The following is a description of a gene set: Mouse Gene Set: SP5_TARGET_GENES Genes containing one or more binding sites for (Sp5) in their promoter regions (TSS -1000,+100 bp) as identified by GTRD version 20.06 ChIP-seq harmonization. from publication Yevshin I, Sharipov R, Kolmykov S, Kondrakhin Y, Kolpakov F (PMID 30445619) studied in species Mus musculus, and this is the list of marker genes: Pycr3 (NCBI Gene Id 67195), Raph1, Tiam1, Rtn4, Ajuba, Mxd3, B3gnt5, Tcea1 (NCBI Gene Id 21399), Fhl3, Arhgef2, Gas2l1, Igsf1, Ube2ql1, 1700066B17Rik, Cyyr1, Kcnb1, Maoa, 3110083C13Rik, Smox, Fars2, Pkib, Fgfr1, Resf1, Naprt, Srpk1, 2310074N15Rik, Wdr76, Irx2, Nyap1, Pabpc1, Fgfr4, Edn2 (endothelin 2), Ifitm1, Bcap31, Mef2c, Usp27x, Gsn, Lrba, Phyhd1, C1ql4, Agps, Pnkd, Lama1, Map2k4, Gm15567, Caprin2, Fzd2, Eea1, Itga2b, Gm5533, Inpp5k, Mertk, Prox1, Gm11733, Acy1, Tesk1, E2f5, Gm25894, Paqr8, Dst, Gng13, Plpp3, Brsk1, Hpcal1, Gm23470, Add3, Syne2, Emilin1, Plin2, Islr, Kctd5, Impdh2, Dcakd, Rnf44, Ggnbp2, Gm26708, Igf2r, Cpeb2, Pald1, Ogfrl1, Rbpms, Elf1, Gmfg, Yap1, C130083M11Rik, Btbd2, Ccdc71, Mov10, Gm10863, Unc5a, Arhgap12, Naalad2, Nrtn, Nr6a1, Tmprss2, Mir1943, Zdhhc20, Ccdc9, E2f1, C2cd2l, Unc119, Haglr, Gm2a, Nectin3, Esd, Kcnn2, Prr29, Has3, Pkd1, Slc29a1, Cln6, Lmbrd2, Zfp551, Megf8, Ldlrap1, Gja1, Rgs3, Itprid2, Rassf10, Dok4, Ift57, Adamts6, Fam169b, Anapc7, Ccnd2, Traf4, Ephb3, Foxn3, Gm24432, Nkiras2, Tubg1, Manea, Fbxo21, Vkorc1l1, Ctif, Greb1, Slc30a10, Tbc1d16, Nfkbiz, Taf8, Pcgf5, 2610528J11Rik, Nckap5l, Dnaaf5, Itpka, Gm10748, Scrt1, Kmt5c, Rian, Grb2, Dock9 (dedicator of cytokinesis 9, NCBI Gene Id 320710), Hexa, Snapc2, Chaf1b, Tmeff1, Set, Phldb1, Col16a1, Tmem198, Csnk2a1, Tma16, Uchl1, Mapk8ip2, Slc2a1, Gm26881, Elovl6 (ELOVL fatty acid elongase 6), Nfia, Vamp4, Atp13a3, Nectin2, Metrnl, Tbl1xr1, Tead2, Gm20109, Galk1, Hid1, Ripk2, Sertad1, Copg2, Usp31, Gatad2a, Ccng2, Actr2, Pkm, Rgs12, A530072M11Rik, Mpc2 (mitochondrial pyruvate carrier 2), Pim1, Fstl1, Snx30, Tppp, Trip12, Cpz, Septin9, Anks1 (NCBI Gene Id 224650), Cyp3a13 (NCBI Gene Id 13113), Arhgap18, E130018N17Rik, Pef1, Hspbp1, Vgll3, A330074K22Rik, Mindy2, Sox12, Mtss2, Arhgap1, Gm26224, Wdr45b, Tsga10, Adra2b, 1500002C15Rik, Tcn2, Ppif, Dhx35, Eif1a, Gfra2, Lsp1 (NCBI Gene Id 16985), Abhd17c, Pipox, Spint2, Asxl1, Tpbgl, Gja5, Gm14379, Serpina3i, C2cd2, Pam, 5730471H19Rik (RIKEN cDNA 5730471H19 gene), Trim62, Bcam, Ogfr, Nes, Gpr157, Tns1, Sult5a1, Fzd10, 4930544D05Rik, Sirpa, Plcxd1, Prdm9, Map3k14, Gm9889, Cnpy1, Ern1, Cdkn2d, Fbxl3, Trim41, Atl2, Slc16a9 (solute carrier family 16 (monocarboxylic acid transporters), member 9), Apbb2, Scaf1, Mycn, Gpat4, AW551984 (NCBI Gene Id 244810), Trim21, Lyrm4, Eomes, 1700041I07Rik, Trim29, Adamts9, Adamts15, Npm3, Ddx20, Mir8102, Trerf1, Jph4, Adprh, Ccdc40, Mir484, Uap1l1, Tmx4, Trp53cor1, Fmo5, Frmd6, Gm25855, Svop, Socs2, Psma2, Spsb1, Tmem26, Cxcl12, Mir135b, Ptpn4, Xylt2, Glra1, Bri3, Spmip8, Plekhh2, Wipf3, Hdac5, Arf1, Otud1, Adamts16, Ddr1, Klhdc10 (NCBI Gene Id 76788), Gcnt1, Bcl3, Speg, Krt19, Mir7240, Mapk8, Emx2, Col13a1, Mtmr4, Pdlim1 (PDZ and LIM domain 1 (elfin)), Tmem151a, Zfp804b (zinc finger protein 804B, NCBI Gene Id 207618), Ankle1, Mgarp, Etv1, Bmp7, Mir3098, Eva1b, Snx21, Lypd1, Ppp1r9b, a, Hs6st1, Cd300lg, Slco4a1, Elk4, Zswim6, Sh2d3c, Dleu2, Macrod2, Rbm38, Gm8177, Notch1, AI480526, Fbxw8, Thra, Fnbp1, Tspan14, Evx1os, Chchd7, Marf1, Gm17344 (NCBI Gene Id 115486898), Has2, Nudt7, Tpst2, Snx6, Gm16084, Arl4c, Slc17a5, Mir1191b, Prox1os, Ppdpf, Atp9b (ATPase, class II, type 9B), Gm23034, Setd1a, Phc1, Mfsd6l, Gse1, Zfp652, Spire2, Ndufa4l2, Gpr21, Klf10, Pdzk1, Jarid2, Trrap (NCBI Gene Id 640386), Car14, Tmem132c, Hycc2, Mir499, Zfp367, Tyro3, Tpd52, Ncf2, Zfp687, Kazn (NCBI Gene Id 71529), Cyrib, P2ry2, Wfikkn1, Map1lc3a, Pde4b, A430057M04Rik, Mdk (NCBI Gene Id 17242), Mir7655 (NCBI Gene Id 102466840), Chrnb4, Mthfr, Lrrc8e, Glipr2, Macf1, Slc22a5, Optn, Eddm13, Srms, Ly6e, Mafb, Llgl2, Adipor2, Crybg2, Epha2, Klhdc8b, Itga3, Pawr, Gm25867, Shmt1, Cacnb3, Adgrb1, Gxylt1, Tmem119, Mmd (monocyte to macrophage differentiation-associated), 6720483E21Rik, S1pr3, Psap, Gm14137, 4933439C10Rik, Mfap3, Tcf7l1, Arhgef17, Vax2os, Fundc1, Trappc9, Tmed7, Lrrn4, Tmcc1, Xylt1, Fgf15, Fam110d, Slc30a3 (NCBI Gene Id 22784), Ada (adenosine deaminase), Them4, Thrap3, Plxnc1 (NCBI Gene Id 80638), Cpm, Rufy4, Ier3, Atg10, Gm53 (NCBI Gene Id 193022), Plekhg5, Nt5e, Rab11fip1, 2900026A02Rik (RIKEN cDNA 2900026A02 gene), Marchf9 (membrane associated ring-CH-type finger 9), 9930012K11Rik, Zfp703, Qdpr (quinoid dihydropteridine reductase), Brd2, Fzd7, Lcp1, Krt24, Ing4, Or2z9, Plag1, Fam210b, Homer3, Lhx5, 2610035F20Rik, Qsox2, 9130017K11Rik, Lrrc63, Eif6, Smagp, Tpi1, Hdlbp, Loxl3, 1110018N20Rik, Man1c1, Mnt, Cpeb1, Dtx4, Ttyh1, Tnfaip8, Khnyn, Plcd3, Wiz, Mfge8, Gm3693, Zfpm1, Mtcl1, Map2, Ndrg2, Gm25857, Vps37b, Atp2c2, Rflna, Mall, Pter, Spred2, Polr2h (NCBI Gene Id 260309), Mfsd4b5, Dusp11, Rbpj, Gm10129, Gm2093, Gab2, Pex5l, Slc29a3, Esam, Zfp462, Icosl, Dab2ip (NCBI Gene Id 98996), 2900041M22Rik, Ptprz1, Tsc1 (TSC complex subunit 1), Fbln1, Gata6os, Smim43, Ints6, Nbeal1, Cmtm6, Tmem139, Sox21, Ptk7, Ip6k2, Kdm3a, Dpm1, Arhgap29, Lrrc38, Gfod1, Pdp1, Hmg20b, Gjc1, Cgn, Usp2, Naaa, Zbtb37, Lrrc8d, Srrm4 (NCBI Gene Id 78602), Zfp281, Lrp2, Mrpl14, Cers1, B230112G18Rik, Sbk1, Cimip4, Palld, Foxd2, Klhl36, Cdkl3, Ost4, Trp53bp1, Plk3, Kcnq1, Ralgapa2, Rbfox2, Tshz3, Gm10637, Fam114a1, Zp3, Slc2a3, Rps15a, Afg3l2 (AFG3-like AAA ATPase 2), Cttnbp2, Gm27242, Rnf31, Rwdd3, Pdzd2, S100pbp, Tmem158, Mospd1, Tc2n, Mir6349, 4933440N22Rik, A830031A19Rik, Tppp3, Mst1r, Firrm, Shroom3, Slc12a4, Mbd6, Uhrf1, Usp43, Dlc1, Etv4 (NCBI Gene Id 217208), Osr2, Dap3, Cmss1, Gas1, Hibadh, Usp37, Elmo3, Sp5, Rimoc1, Sinhcaf, Moxd1, Hivep1, Itgb5, Rif1, Fbxo43, Pou5f1, Gm12292, Ppp4r1l-ps, Slc8a2, Arhgap39, Ccndbp1, Tmem30b, Dgkz, Mpst, Tle6, Mtres1, Ropn1l, Tmtc2, Sp6, Osbpl3, Prss8, Ncam1, Pdk1, Abl2, Skp2, Sema3f, Med6, Ankk1, Gm20652, Acsl1, Osbpl10, Tgif2, Pias1, Zfp652os (NCBI Gene Id 432396), Srl, Gm28340, Cdkn2aip, Cbln3, Angel1, Slc29a4, Kank2 (KN motif and ankyrin repeat domains 2), Rps19, Zfp185, Cul4a, Tgfbr3, Eno2, Zfp946, Myo19, Mphosph6, Lrrfip1, Apbb1, Tspan17, Vangl1, Akr1c19, Nucks1, Baz1b, Tpm2, Nkx2-1, Pbx2, Garnl3, Plec, Bag3, Ctnnbl1, Rassf4, Lsm14b, Gas5, Gdpgp1, Pbx1, Tmem240, Gm15912, Neurog1, Vgll4, Sox11, Fam114a2, Yars1, 2500004C02Rik, Smg1, E030042O20Rik, Igsf10, Dok5, Gm15663, Grsf1, Bend5, Grb7 (growth factor receptor bound protein 7), Mepce, Cd52, Tmem63b, Mapk1, Crmp1, Nt5c2, Tef (NCBI Gene Id 66951), Eloa, Tex15, Nhsl1, Tsc22d4, Il17rc (NCBI Gene Id 76314), Mmp28, Sntb2, Prr5l, Rbm15b, Gm15941, Sema6a, Ing2, Kdelr2, Spry4 (NCBI Gene Id 328944), Adgrg1, Slk, T2, Gm34086, Lama5 (NCBI Gene Id 99115), Gm10010, Sowahc, Mme, Cpt1c, Ctbp2, Ndufb3, Pygo2, 5730420D15Rik, Pard3bos2, Phlpp2, Layn, Efhc1 (EF-hand domain (C-terminal) containing 1), Gm22082, Grip1, Scarb1, Slc13a2, Zfp385a (NCBI Gene Id 29813), Cib1, Mfap3l (NCBI Gene Id 71408), Sox7, Tnk2, Hsp90ab1, Arrb2, Wwtr1, Lhfpl5, Nanog, 4930412F09Rik, Cthrc1, Chst15, Amotl2, Snhg11, Cep70, Ralbp1, Vps13d, 4833418N02Rik, Dusp3, Rab43, Gm15541, Chsy3, Raly, Exo5, Acbd4, Kctd6, Eva1c (eva-1 homolog C), F3, Crabp2, 1700001O22Rik, Ust, Cbx7, Urah, Atr, Camsap3, Pik3cd, Gm12063, Zfp467, Atp5pb, Lmnb1, Fndc10, Nme4, Hoxb13, Atp2a3, Med26, Prkar1b, Fhod3 (NCBI Gene Id 269001), Tob2, Cers5, Rabgap1, Nradd, Cltc (clathrin heavy chain), Tmem123, Cerkl, Lratd1, Stat5a, 1700008O03Rik, Ripply1, Tfr2, Sema6d, Carmil1, Clcn2, Mir6991, Bin1, Tox2, Fbxo36, Lrrk2, Tbx3, Mapk9, Ypel1, Sqor, Gm17733, 2310069B03Rik, Hmgxb4, Mbd2, Abcd1, Cops6, Cacnb2, Kmt2a, Lemd1, Faap100, Fads2, Fbxl19, Gm16096, Clic4, 9130019P16Rik, Kif26a, Atp11b, Tst (NCBI Gene Id 22117), Zfp408, Fscn1, Dpp6, 1700123M08Rik, Fgfr1op2, Trim6, 2310022B05Rik, Gga2, Tprgl-ps1 (transformation related protein 63 regulated like, pseudogene 1), Trip10, Adcy3, Nbeal2, Tcte2, Golm2, Alox5ap, Stk32a, Ssh2, Calcoco1, Dnai1, H4c16, Tmem63a, Cldn1, Slc9a3, Dennd11, Arhgap28 (Rho GTPase activating protein 28), Gpc5, Gdf6, Znrf3, Fgf4, B4galt7, Kcnj3, Rnf114, Gprin1 (G protein-regulated inducer of neurite outgrowth 1), Hyi, Cd82, 4930589L23Rik, Pskh1, Mtf2, Slc3a2 (solute carrier family 3 (activators of dibasic and neutral amino acid transport), member 2), Mybphl, Slc2a13 (NCBI Gene Id 239606), Tmem192, Mlf2, Mcf2l, Etv5, Foxp2, Foxo6, Syn2, Hspb9, Fgfr2, Sulf1, Slc48a1, Adam19, Dut, Apoe, Gabra4, Tlr2, Mybl2, Nmb, Gja4, Tbc1d14, Vav2, Notch3, Mrpl32, Plp1, Gigyf2, Atp2b4, Pitx3, Glis2, Tmem184a, Dcaf6, Rassf2, Lman1, Rps6ka3, Gm26562, Narf, Nfe2l2, Lef1, Gm22489, Arpc5l, Aim2, Sbk2, Dstn (NCBI Gene Id 99231), Rab3il1, Kctd15, Cpq, Htra1, Inppl1, Smim27, Rbx1, Acot11, Dand5, Rasgrp2 (RAS, guanyl releasing protein 2), Tmem63c, Ikzf2, Atp5mc3, Fgfr3, Auts2, Zic4, Atpaf2, Ptpn6, Atosb, Scube3, Pgf, 4930583K01Rik, Mbtd1, Zbtb20, Col8a1, Tjp2, Chpf, Rasal2, Zic3, Pld6, Gm16143, Cyp46a1, Bhlha15, Zfp36, Camsap1, Tmem45a, Pip4p2, Lonp1, Cst3, Pabpc4, Ctnnal1, Spata2l, Arhgef1, Hoxb9, Socs3, Prdm4, Dok1 (NCBI Gene Id 13448), Usp7, Espn, Myl2, Crtap, Utf1, Rarg, Ifi27l2a, Large2, Ap1g2, Pigw, Gdi1, Lrrk1, 4930527A07Rik, Slc8b1, Ell3, Zfp688, Rab38, Setx, Ndrg1, Myadm, Numbl, Pcid2, Cpne3, A730013G03Rik, Bola2, Ptafr, Mir574, 4930579F01Rik (RIKEN cDNA 4930579F01 gene), Prex1, Tcea3, 2810025M15Rik, Anxa11, E230001N04Rik, Kcne5, Gm11524, Notch2, Dkk1, Ccdc92, Flrt2, Anxa7, Gm16046, 1700065D16Rik, Top6bl, Foxd2os, Sptb, Gm14342, Dll4, Ywhaz (tyrosine 3-monooxygenase/tryptophan 5-monooxygenase activation protein, zeta polypeptide), Zc3hc1, Ahdc1, Shcbp1l (NCBI Gene Id 71836), S1pr1, Fnip2, Myb, Cripto, Ubxn1, Tnfrsf12a, Taf11, Nbea, Ttc9b, Zfp524, Mettl18, 5031434O11Rik, Retreg3, Slco5a1, Nub1, Mfsd2b, Tfap2a, Mrnip, Agpat2, Rab22a, Lamc1, Dennd4c, Altre, Lrp1, Oaf, Itga1, Ctdsp2, Zfp664, Six1, Prickle1, Trib1, Osbpl8, Galk2, Eepd1, Gabrb3, Aplnr, Gm9955, Smarce1, L1td1, Cep170b, Acp5, H4c2, Tfdp2, Ncor2, Fiz1, Gata6, Six5, Gm16897, Nadk, Plekhg2, Col18a1, Rnf135, Tmem132d, Septin2, Ldb1, 1810059C17Rik, Gm22357, Wdr77, Psme2, Gid4, Tmub1, Calm1, Ttc7, Ildr1, Poc1a, Igf2bp3, Usp12, Zfp36l1, Gnai2, Rrbp1, Nmnat3, Axl, Slc1a5, Ogfod2, 6330409D20Rik, Mrc2, Fam43b, Stx16, Amot, Atoh1, Amz2, Bmp4, Nopchap1, Paqr5, Crocc (NCBI Gene Id 230872), Timmdc1, Pou2f1, Gm25336, Llgl1, Dync1h1, Gpr75, Smoc2, Uba3, Timm50, Hif1a, Crym, Pip4k2b, Vasp, Vax2, Syne1, Sipa1, Cplane2, Arid3a, Usp22, Ube2e1, Fev, Fbrsl1, Pias3, Magi1, Fbxo41, Kcnq3, Hs3st1, Taok3, Zfp36l2, Gm22319, Acads